Given this list of marker genes ENPP2, DIP2B, ZZZ3, UBR1, C4orf46, UBE2W, ETS1, OGFOD1 (NCBI Gene Id 55239), PABPC3, ATRN, NAP1L3, EIF2AK3, PAPOLB, TBCCD1, TP53RK (TP53 regulating kinase), PHF14, TMEFF1, KHDRBS1, CBL, SSH1, IP6K3, AMOT, ITPRIP, UBXN10, VIL1 (villin 1), INAFM2, LHX2, FAM120A, RAP1B, NLGN4Y, RAP1GDS1, ZNF680 (NCBI Gene Id 340252), LARP1, COLGALT2, PLRG1, GRM1, GPT2, GNRHR, MSANTD3-TMEFF1 (NCBI Gene Id 100526694), NAA50, PTCD2, CLGN, FTO, SLC6A15, ZNF664, PABPC1, RFTN1, ZNF74, NID1, ZHX2, GLRA2, here is a description of the gene set: Genes predicted to be targets of miRBase v22 microRNA hsa-miR-4759 in miRDB v6.0 with MirTarget v4 prediction scores > 80 (high confidence targets). Human Gene Set: MIR4759 from publication Chen Y, Wang X (PMID 31504780) species: Homo sapiens